Given this list of marker genes Draxin, Cx3cr1, Trem2, Parp2, Stambp (STAM binding protein), Elk1, Lcn2, Cx3cl1, here is a description of the gene set: Any apoptotic process that occurs in a hippocampal neuron. studied in species Mus musculus Mouse Gene Set: GOBP_HIPPOCAMPAL_NEURON_APOPTOTIC_PROCESS